The following is a description of a gene set: Human Gene Set: GOCC_RNA_N6_METHYLADENOSINE_METHYLTRANSFERASE_COMPLEX A RNA methyltransferase complex that catalyzes the post-transcriptional methylation of adenosine to form N6-methyladenosine (m6A). In budding yeast, the MIS complex consists of Mum2p, Ime4p and Slz1p. In vertebrates, the complex consists of METTL3, METTL14 and associated components WTAP, ZC3H13, VIRMA, CBLL1/HAKAI and in some cases of RBM15 (RBM15 or RBM15B). studied in species Homo sapiens, and this is the list of marker genes: METTL3, WTAP, METTL4, VIRMA, CBLL1, ZC3H13 (zinc finger CCCH-type containing 13), METTL14, RBM15B, RBM15